Given this list of marker genes Col1a2, Col3a1, Col2a1, Col11a1, Col28a1, Lum, Col5a1, Col5a3, Col1a1, Col11a2, Col5a2, Col27a1, here is a description of the gene set: Any triple helical collagen trimer that forms fibrils. Mouse Gene Set: GOCC_FIBRILLAR_COLLAGEN_TRIMER species: Mus musculus